Given this list of marker genes MYO5B, TRMT6, GRIA4, TMEM273, KCND2, PSPC1, SCAF8, LYPD6, AHCTF1, HOXB9, DNAL1, GABPA, NEUROG1, RIMKLB, PDCD2, EGFR, SLC9A6, SSBP2, TTC19, DGKE, RRAGC, NR5A2, LRRC69, EXD1, KCNIP1, IRAG2, MTAP, MAPK9, HAS2, IFNAR1, ARHGAP28, AMMECR1 (NCBI Gene Id 9949), SMIM21, TARDBP, RNF217, CDNF (cerebral dopamine neurotrophic factor), CCR9, MSANTD3, TMEM154, CYP1B1, FBXL5, PATZ1, ADGRF1, LMO4 (LIM domain only 4), WDR64, ZNF318, SDHD, FAM210A, ATP8A2, CUX1, PHF20, TMEM132B, DAG1, ITGA9, CRIM1, TTC14, RBM27, RPGRIP1L, TNFRSF10C (NCBI Gene Id 8794), ZSCAN30, NRBF2, CLCA2, NECTIN3, TFAP2B, ANXA6, AGO1, LMLN, STXBP5L, ILRUN, YTHDF2, BNIP2, MXI1, HSCB, SNX13, FRRS1L, KIF1B (NCBI Gene Id 57598), SRP19, RBM3, KATNBL1, CHST2, CAB39, SKIL, TATDN3, MDM4, MYO19, CAMK4 (calcium/calmodulin dependent protein kinase IV), LYN, TCF19, DSTYK, ZNF503, PAN3, PRKCE, ZIC2, ENSG00000275993, ZFAND5, NEUROD1, NDST3, PDE4DIP, TNRC6C, ARID1B (NCBI Gene Id 645070), KDSR, DPP10, MAP2, ANK3, ANKRD34C, SLC35F5, PCDH11X, FBXO32, CDKL5, LPAR1, FLI1, DGKH, CDON, PSD3, MEST, TANC2, MALT1, MYO5C, NUDT13, BTG2, DDX3X, DENND10, ADIPOR1, SRSF12, QRICH1, UBN2, SMOC1, PIKFYVE, ARMCX3, FXR1, NRG1, EIF3H, AP2B1, ADAMTSL3 (NCBI Gene Id 57188), P3H2, DNAJB4, ANGPT1, SLC38A9, CSF1, IL36B, LRIG2, SND1, AAK1, EAPP, CCDC6, NIPAL1, TAB2, DACH1, PINX1, FST, LRRC59, RASGRP3, WBP1L, ARHGAP20, TOX, B4GALT6, NUDCD2, NFIB, THAP1, TRAF3, ZMAT4, TENT5A, HDAC9, ADK, EPN2, HDAC7, WDFY1, PF4, PTK2, NAA35, CCDC43, FUT9 (fucosyltransferase 9), MTR, CDK17, TIGIT, LZTS2, IPMK, ZMYND8, PRG4, CRADD, SOAT1, DMXL2, COPZ1, TDG, RBM41, FOXD2, DSTN, ELK1, BCL2L2, CLIC5 (NCBI Gene Id 53405), ZBTB20, PTCHD4, ENSG00000236754, NRF1, MAN2A1, TSHZ2, HMGCR, ANKHD1, ACVR1C, ARMC1, RPL7L1, RUFY3, DTWD2 (DTW domain containing 2), RBM15, RIOX2 (ribosomal oxygenase 2), SPTY2D1 (NCBI Gene Id 144108), PID1, TSPAN14, PIK3R1, UNC13C, EEA1, ZNF705D, KCNA5, IGSF10, PHACTR4, FLG, RAB40B, ZDHHC23, ULK2, IKZF2, CDK14, TNRC6B, NCOA1, DNAJC18, SLC17A4, WDR7, MANEA, PRRX1, TMEM70, ANKRD30A, UNC80, FNBP1L, RREB1, ID4, ANO3, BRWD1, PCDH15, GRM1, ARID4B, CDC14B, SPAG9, RNPC3, BRPF1, TPM3, GPR55, SPIN3, CYP27C1, HAUS5, FAM98A, SETBP1, CCPG1, LPIN2, CEP41, OCRL (OCRL inositol polyphosphate-5-phosphatase), NCOA3, RBMS3, MPRIP, SELP, P2RY10 (NCBI Gene Id 27334), PTGFRN, CTSS, G3BP1, UBE2H, TEAD1, MOB1B, ITPR2, ANTXR1, TCHP, SH3GL2, BABAM2, ZFP62, PAK3, PTPRD, DIO2, EML5, SUZ12, UGT8, CCDC15, VXN, TGFB2, ACSM2A, CALD1, GPR52, PRKX, SETD9, B3GLCT, NOLC1, TIMM8A, MAP3K7, MYOCD, CACNA1C, FCAMR, KPNA3 (NCBI Gene Id 3839), TEC, NFAT5, COL8A1, ZNF704, LIN7C, ERC2, KLHL40, ONECUT2, TOB1, NCK1, RAB22A, LSAMP, NIPSNAP2, GRAMD1C, RBBP5, CRMP1, EPB41L3, MCC, THAP12, CDK19, C16orf87, PTGER3, ROBO2, PCDH9, SOX6, SMTNL2, PDE6C, MTF1, CHD7, SAMD4A, MOB3B, CSRP3, MYBL2, ENDOU, TBC1D2B, GREB1, ERI1, PCYOX1L, CHUK, ZNF22, STAG1, MAK16, USH2A, NUCB2, KIF2A, RBM22, NCAM2, PCTP, CEP126, UROC1, CDH18, GPATCH2L, C11orf87, RGS7, MAIP1, HCFC2, ATXN1, PEA15, SEPTIN10, ACADSB, SLC17A8 (solute carrier family 17 member 8), CDK6, UFSP2, RSPO3, PGGT1B, MLLT10, KCNK2, SCUBE3, FNIP2, TLE4 (NCBI Gene Id 7091), PLXNA4, KCNA4, TMEM132D, FAR1, EPHB1, KDM2A, FYB1 (FYN binding protein 1), COL9A1, AP1M2, PLXDC2, CD34, AK4, POTEA, MSL2, CACHD1, TET2, KLHDC7A, GLB1, CTXN2, ZNF827, TDRD3, UBE2K, EHF, ATP11AUN, CDK2AP1, ZNF629, GYPE, SIK1, CDH17, NPTX1, KIAA1549, CDV3, PWWP2A, CHST9, ADAMTS3, here is a description of the gene set: Genes predicted to be targets of miRBase v22 microRNA hsa-miR-6875-3p in miRDB v6.0 with MirTarget v4 prediction scores > 80 (high confidence targets). from publication Chen Y, Wang X (PMID 31504780) Human Gene Set: MIR6875_3P studied in species Homo sapiens